The following is a description of a gene set: Reduced forced expiratory volume in one second An abnormal reduction in the amount of air a person can forcefully expel in one second. Human Gene Set: HP_REDUCED_FORCED_EXPIRATORY_VOLUME_IN_ONE_SECOND studied in species Homo sapiens, and this is the list of marker genes: RTEL1, FCGR2A, CEACAM6, GCLC (glutamate-cysteine ligase catalytic subunit), GSTM3 (NCBI Gene Id 2947), HMOX1, EDNRA, PIEZO2, KCNN4, HES7, SLC6A14, PARN, CSF2RA, NEK10, STX1A (syntaxin 1A), CLCA4, CEACAM3, HFE, TGFB1, CFTR, ITCH, SLC9A3, PABPN1, SLC11A1, DCTN4, DNAH9, MIF, SLC26A9, SERPINA1, STK36